Given this list of marker genes HGD, NOTCH1, HAAO, IDUA, ADAMTSL2, LZTR1, UBE2A, ABCC6, KMT2D, ZMPSTE24, MCTP2 (multiple C2 and transmembrane domain containing 2), GBA1, LMNA, ARSB, XYLT2 (xylosyltransferase 2), FBN1, ZNF148, NF1, PLD1, ZIC3, GJA1, SYT2, NKX2-5, CHST3, XYLT1, NOTCH2, KDM6A, here is a description of the gene set: Mitral stenosis studied in species Homo sapiens Human Gene Set: HP_MITRAL_STENOSIS An abnormal narrowing of the orifice of the mitral valve.